Given this list of marker genes CCR8, JCHAIN, PSPHP1, NCF1C, NFKB2 (NCBI Gene Id 4791), RHOBTB3, YY1, CDC6, GNA13, GATM, ZNF217, TRIM25, ANKRD17, here is a description of the gene set: ANBL-6, a myeloma cell line, proliferates in response to interleukin 6 (IL-6) stimulation, coculture with bone marrow stromal cells, and when harboring a constitutively active mutant N-ras gene. Eighteen samples, including 4 IL-6-treated, 3 mutant N-ras-transfected, 3 normal stroma-stimulated, 2 multiple myeloma (MM) stroma-stimulated, and 6 untreated controls were profiled using microarrays interrogating genes. Global hierarchical clustering analysis distinguished at least 6 unique expression signatures. Notably, the different stimuli altered distinct functional gene programs. Class comparison analysis (P =.001) revealed genes (54% involved in cell cycle) that distinguished IL-6-stimulated versus nontreated samples. Eighty-seven genes distinguished stroma-stimulated versus IL-6-treated samples (22% encoded for extracellular matrix proteins). A total of genes distinguished N-ras transfectants versus IL-6-treated samples (26% involved in metabolism). A total of genes, 20% of these involved in signaling, distinguished N-ras from stroma-interacting samples. All 3 stimuli shared genes, mostly of metabolic function. Genes that distinguished MM1 from MM4 clinical groups were induced at least by one treatment. Notably, only genes (ETV5, DUSP6, and KIAA0735) are uniquely induced in mutant ras-containing cells. We have demonstrated gene expression patterns in myeloma cells that distinguish an intrinsic genetic transformation event and patterns derived from both soluble factors and cell contacts in the bone marrow microenvironment. from publication Croonquist PA, Linden MA, Zhao F, Van Ness BG (PMID 12791645) Genes down-regulated in ANBL-6 cell line (multiple myeloma, MM) co-cultured with bone marrow stromal cells compared to those grown in the presence of IL6. species: Homo sapiens Human Gene Set: CROONQUIST_STROMAL_STIMULATION_DN